The following is a description of a gene set: Mouse Gene Set: GOBP_POSITIVE_REGULATION_OF_STEROID_HORMONE_BIOSYNTHETIC_PROCESS studied in species Mus musculus Any process that increases the frequency, rate or extent of the chemical reactions and pathways resulting in the formation of steroid hormones,compounds with a 1, 2, cyclopentanoperhydrophenanthrene nucleus that act as hormones., and this is the list of marker genes: Por, Gh, Bmp6, Cyp17a1, Igf1r, Wnt4, Igf2, Nr5a2, Dab2, Igf1